The following is a description of a gene set: Mouse Gene Set: GOBP_PHASIC_SMOOTH_MUSCLE_CONTRACTION studied in species Mus musculus A process in which force is generated within phasic smooth muscle tissue, resulting in a change in muscle geometry. Force generation involves a chemo-mechanical energy conversion step that is carried out by the actin/myosin complex activity, which generates force through ATP hydrolysis. In the phasic smooth muscle, the muscle contraction occurs without an ordered sarcomeric structure. Phasic smooth muscle contraction occurs in a series of discrete contractions and relaxations., and this is the list of marker genes: Neurog1, Htr2b, Drd2, Dlg1, Edn3, Kit, Scn11a (NCBI Gene Id 24046), Tifab, Edn1, Tshz3, P2rx3, Ptger4, Tacr2, Ghrl, Npy1r, Gdnf, Sstr2, P2rx2, Edn2, Tbx3, Tbx2, Drd1, Ednrb, Ptger3, Htr7, Ghsr, Kcnma1, Htr1d, Agt